The following is a description of a gene set: Human Gene Set: HP_HAMARTOMA_OF_THE_EYE Hamartoma of the eye species: Homo sapiens A hamartoma (disordered proliferation of mature tissues) which can originate from any tissue of the eye., and this is the list of marker genes: MDH2, KLLN, DLST, SDHB, SDHAF2, TMEM127, SPRED1, RET, USF3, SLC25A11, SDHA, SEC23B, VHL, PIK3CA, TSC1, NF1, TSC2, SDHC, KIF1B, KRT1, AKT1, SDHD, MSH6, FH, MAX, NF2, IFNG, KRT10, CCND1, PTEN